Given this list of marker genes SQSTM1, CHMP2B, CHMP6, CHMP4B, CHMP3, CHMP4C, CHMP5, CHMP4BP1, CHMP7, LRRK2 (leucine rich repeat kinase 2), CHMP1B, CHMP1A, CHMP2A, CHMP4A, here is a description of the gene set: species: Homo sapiens Intermediate organelles formed during macroautophagy through the fusion between autophagosomes and endosomes. Human Gene Set: GOCC_AMPHISOME